Given this list of marker genes ERCC8, LMNA, TONSL, LEMD3, EBP, NGLY1, SLC34A2, EIF2AK3, SRCAP, TRPS1, ERCC6, GJA1, here is a description of the gene set: studied in species Homo sapiens Sclerosis of hand bone Human Gene Set: HP_SCLEROSIS_OF_HAND_BONE Osteosclerosis affecting one or more bones of the hand.